Given this list of marker genes PTEN, PIP4P1, TPTE, INPP5F, FIG4, MTMR14, INPP5D, MTMR3, MTM1, SACM1L, INPPL1, PTPRQ, TPTE2, SYNJ1, MTMR6, MTMR2 (NCBI Gene Id 8898), MTMR10, MTMR4, MTMR11, MTMR12, INPP5K, INPP4B, PTPMT1, PIP4P2, PIKFYVE, MTMR1, MTMR7, INPP5E, MTMR8, SYNJ2, INPP5B, INPP4A, OCRL, INPP5J, here is a description of the gene set: species: Homo sapiens Human Gene Set: GOMF_PHOSPHATIDYLINOSITOL_PHOSPHATE_PHOSPHATASE_ACTIVITY Catalysis of the reaction: phosphatidylinositol phosphate(n) + H2O = phosphatidylinositol phosphate(n-1) + phosphate. This reaction is the removal of a phosphate group from a phosphatidylinositol phosphate.